The following is a description of a gene set: from publication Gavish A, Tyler M, Greenwald AC, Hoefflin R, Simkin D, Tschernichovsky R, Galili Darnell N, Somech E, Barbolin C, Antman T, Kovarsky D, Barrett T, Gonzalez Castro LN, Halder D, Chanoch-Myers R, Laffy J, Mints M, Wider A, Tal R, Spitzer A, Hara T, Raitses-Gurevich M, Stossel C, Golan T, Tirosh A, Suvà ML, Puram SV, Tirosh I (PMID 37258682) Genes upregulated in subsets of cells of a given type within various tumors Human Gene Set: GAVISH_3CA_METAPROGRAM_B_CELLS_STRESS species: Homo sapiens In this study, an extensive analysis was conducted to define meta-programs (MPs) capturing intra-tumor heterogeneity across a spectrum of tumor types. The approach utilized non-negative matrix factorization (NMF) to analyze each cell type separately within individual tumor samples. This involved the analysis of malignant cells, macrophages, fibroblasts, endothelial cells, epithelial cells, T-cells, and B-cells. NMF was executed with varying parameter values (K=4, 5, 6, 7, 8, 9), thereby generating 39 programs for each cell type per sample. Each NMF program was summarized by the top genes based on NMF coefficients.\nRobust MPs were then delineated for each cell type using a set of stringent criteria, including recurrence within the same tumor, similarity to programs in other tumors, and non-redundancy within a tumor. Subsequently, these robust NMF programs were clustered (per cell type) based on Jaccard similarity, leading to the identification of MPs associated with each cell type.\nTo enhance the quality of the MPs, a refinement steps were undertaken, involving the removal of MPs suspected of reflecting low-quality data (with an overrepresentation of ribosomal proteins or mitochondrial-encoded genes), single-study inclusion, or similarity to miss-annotated cell types., and this is the list of marker genes: FOSB, VPS37B, LY9, IL4R, FCMR, JUN (NCBI Gene Id 3725), GADD45B, DUSP2, CD69 (CD69 molecule), ZFP36, YPEL5, DUSP1, VPREB3, SNX2, CD72, CCR7, IER2, FOS, JUNB, NR4A1, GPR183, CREM, KLF2, TCL1A, FCER2, BTG2, RHOH, SELL, NFKBIA, CD55, FOXP1, IGHM, TSPAN13, AREG, KLF6, CLEC2D, IGHD, CD83, LINC00926, SLC2A3, ZFP36L2, ZNF331, PHACTR1, BIRC3, NR4A2, ADAM28 (ADAM metallopeptidase domain 28), CD22, RGS2, PPP1R15A, HVCN1